Given this list of marker genes TLR5, MAMDC2, PTH2R, CNN1, CA14, TNFRSF8, TRIM46, MIOX, NCKAP5, PTGS1, RGS8, OR10AC1, WNT8A, KCNJ2, PTPRR, C11orf87, VAV1, MC4R, ADAMTS16, KLHL1, MST1, UCP1, KCNJ5, FIBIN, RHOJ, ADARB2, MFSD2B, SPINK2, CRYGN, DKK1, ERICH5, PRSS36, FGL2, SLFN5, CHST3, ISLR2, PAMR1, PTN, PDZD7, ERICH6, GRM3, KCNAB1, FGF10, ABCC3, NRBP2, MST1R, HCAR1, SNCA, PCDHGA1, FXYD5, LOXL3, LAMA4, GUCY1A1, TCAM1P, KCNK10, TNFRSF13C, ESR2, RFLNA, ISLR, PAK5, SCNN1A, CIITA, TMEM63C, OPCML, NOTO, KCND2, YPEL4, HOXB13, CHODL, SLC2A10, CLEC14A, TEKT2, LTA, COL4A3, TPPP3, OR2B11, NOL3, MEIS1, NPY2R, LYL1, MOGAT1, BRINP3, COL7A1, CRYAA, OSBPL5, PROKR1, GNAT1, TMEM26, BICDL2, ITIH5, ROBO2, ALOX15B, CRABP2, CACNB3, PDE11A, GPR84, CDKN2C, CNMD, GAS2L2, CD44, TGFB3, COL4A4, PDYN, TRIM15, TGM1, PHYHIP, MRGPRE, CALY, MEGF10, SOX17, ZNF354B, EDN2, ADAM33, EXTL1, KLHL5, COL24A1, CIMIP2B, PLCXD3, REM2, FOXS1, TMEM45B, PSMB11, TMEM125, ETV2, here is a description of the gene set: Somatic cells can be reprogrammed to a pluripotent state through the ectopic expression of defined transcription factors. Understanding the mechanism and kinetics of this transformation may shed light on the nature of developmental potency and suggest strategies with improved efficiency or safety. Here we report an integrative genomic analysis of reprogramming of mouse fibroblasts and B lymphocytes. Lineage-committed cells show a complex response to the ectopic expression involving induction of genes downstream of individual reprogramming factors. Fully reprogrammed cells show gene expression and epigenetic states that are highly similar to embryonic stem cells. In contrast, stable partially reprogrammed cell lines show reactivation of a distinctive subset of stem-cell-related genes, incomplete repression of lineage-specifying transcription factors, and DNA hypermethylation at pluripotency-related loci. These observations suggest that some cells may become trapped in partially reprogrammed states owing to incomplete repression of transcription factors, and that DNA de-methylation is an inefficient step in the transition to pluripotency. We demonstrate that RNA inhibition of transcription factors can facilitate reprogramming, and that treatment with DNA methyltransferase inhibitors can improve the overall efficiency of the reprogramming process. Genes with intermediate-CpG-density promoters (ICP) bearing the bivalent tri-methylation marks at H3K4 (H3K4me3) and H3K27 (H3K27me3) in MCV8.1 cells (induced pluripotent cells, iPS). from publication Mikkelsen TS, Hanna J, Zhang X, Ku M, Wernig M, Schorderet P, Bernstein BE, Jaenisch R, Lander ES, Meissner A (PMID 18509334) Human Gene Set: MIKKELSEN_IPS_ICP_WITH_H3K4ME3_AND_H327ME3 studied in species Mus musculus